The following is a description of a gene set: We report the application of single-molecule-based sequencing technology for high-throughput profiling of histone modifications in mammalian cells. By obtaining over four billion bases of sequence from chromatin immunoprecipitated DNA, we generated genome-wide chromatin-state maps of mouse embryonic stem cells, neural progenitor cells and embryonic fibroblasts. We find that lysine 4 and lysine 27 trimethylation effectively discriminates genes that are expressed, poised for expression, or stably repressed, and therefore reflect cell state and lineage potential. Lysine 36 trimethylation marks primary coding and non-coding transcripts, facilitating gene annotation. Trimethylation of lysine 9 and lysine 20 is detected at satellite, telomeric and active long-terminal repeats, and can spread into proximal unique sequences. Lysine 4 and lysine 9 trimethylation marks imprinting control regions. Finally, we show that chromatin state can be read in an allele-specific manner by using single nucleotide polymorphisms. This study provides a framework for the application of comprehensive chromatin profiling towards characterization of diverse mammalian cell populations. studied in species Mus musculus Human Gene Set: MIKKELSEN_ES_ICP_WITH_H3K4ME3 from publication Mikkelsen TS, Ku M, Jaffe DB, Issac B, Lieberman E, Giannoukos G, Alvarez P, Brockman W, Kim TK, Koche RP, Lee W, Mendenhall E, O'Donovan A, Presser A, Russ C, Xie X, Meissner A, Wernig M, Jaenisch R, Nusbaum C, Lander ES, Bernstein BE (PMID 17603471) Genes with intermediate-CpG-density (ICP) promoters bearing histone H3 K4 trimethylation mark (H3K4me3) in embryonic stem cells (ES)., and this is the list of marker genes: LRRC2, GJB5, TRMT10B, SMIM26, GPR143, UPK2, TRAF3IP2, NEIL1, FNDC11, EFCAB12, PBX1, SLC12A6, PYCARD, MED24, TOMM40L, CTNND1, ELMO1, MEGF10, SERPINI1, TCTN2, MPV17, GRN, ZNF276, MAPDA, MGST1, TRPV2, ZBTB4, FBXO16, OAS1, WDR38, DYNC2LI1, SPRED3, NME7, ADPRHL1 (ADP-ribosylhydrolase like 1), CYP2D6, PANK1, ACP3, LY6G6D, PPP2R5C, MVP, ASB15, WASHC3, TLR3, SCN9A, ZNF429, INTS9, DPP7, TMEM154, RCOR2, PM20D1, SACS, PCBD1, TRIM46, SLC22A18, HOGA1, RHBDL2, PRAMEF12, GALE, SETD1B (NCBI Gene Id 23067), TRAK1, RASSF6, GPRIN3 (NCBI Gene Id 285513), DRC3, MMACHC, SLC11A1, TCEAL1, PYROXD2, MTCL3, SLC4A10, SIPA1, LRRC74B, CLCN5, NQO1, ELMO3, CLIC1, SH3BGRL, OOEP, LPAR2, ZNF519, SERPING1, CHRNG, TULP2, PPP1R42, GOSR1, ATOSA, DNAH2, HSPB6, CPT1B, ARHGEF9, CROCC, AGMAT, PSD4, VPS50, SPARC, CAPN1, ZNF317, TCIM, RBM4, APOBEC3B, ADD3, ETV1, CBLN3, ZNF607, CD99L2, TCEAL8, RIN2, TRIM63, CTU1, G0S2, KCTD20, FIS1, NME5, CFAP52, FBXW7, RCN3, KATNAL2 (katanin catalytic subunit A1 like 2), NRSN2, RFTN2, C11orf52, RIOK2, SMUG1, CCDC68, KLC3, AASS, ZFP82, TSPOAP1, CHM, GYPA, TMEM119, SLC17A9 (NCBI Gene Id 63910), ACTR6, NFE2, DYNLT4, SLC44A4, TMEM82, S100A1, INHBE, GAP43, ZC3H12D, RDH12, IDNK, RAB13 (RAB13, member RAS oncogene family), NUDT13, C16orf54, AOX1, SCARF1, BLZF1, DNALI1, RLN2, GTF2H4, TMEM198B, GJB3, FOXH1, NSUN6, GDF3 (growth differentiation factor 3), CRYGN, USP49 (ubiquitin specific peptidase 49), NAT14, MST1, ALOXE3, FAM83E, DDX60, EMP1, MAMDC2, ACSL5, RECQL5, LARS1, GHDC, GSTT1, TLR2, MDH1B, ZFP42, SCN1A, PIERCE1, IL23A, PTER, RNF125, DAPP1, CFAP91 (cilia and flagella associated protein 91), IP6K2, LAT, CD3E, NCCRP1, ELF3, SLC12A3, MT3, LY96, DECR2, FKBP10, ZNF595, RAB19, TRIM29, GPX2 (NCBI Gene Id 2877), NHSL1, MCTS1, ABCD2, CRISPLD1, ABHD14B, CA3, ALDOC, NOBOX, OSGEPL1, PTGES, FASTKD2, MRGPRE, SLC37A4 (solute carrier family 37 member 4), CHRNA9, ARHGAP45, DLG4, PLIN3, APOOL, RTTN, SAT2, LIPH, POU5F1 (NCBI Gene Id 7934), SRRM3, CDH15, FKBP7, GMPPA, CCDC28B, TMEM63C, GSTM5, GEMIN6, DCLRE1C (NCBI Gene Id 64421), FAM13A, ASPRV1, TMEM45A, CPSF4L, RNF208, AGPAT4, ECHDC3, HSD17B11 (NCBI Gene Id 51170), INPP5J, ZNF415, SPHKAP, KCTD14, SLC35G6, CDC42EP5, LAMB2, FAM111A, PCYT1B, CCDC160, ANXA3, INHBC (inhibin subunit beta C), LIMA1, IGBP1, TRAF1, TIMM21, GNG2, THRSP, VPS41, C1QTNF5, TBKBP1, ZMYND8, ATP6V1G2, SSPN (NCBI Gene Id 8082), CPT1C, FUNDC2 (NCBI Gene Id 65991), TRIM6, ZCCHC13, P2RX7, OR2C1, CALD1, COX6B2, SCML4, FGR, CRYZL2P, FOXS1 (forkhead box S1), SLC9B1, LIN52, IGSF23, TBX6, ADM2, OPLAH, HRAS, MTMR11, RBP7, PHC1, GAB3, ZNF182, BMERB1, TMEM69, PCLAF (PCNA clamp associated factor), GPX8, PLEKHG1, BIVM, CD247, STC1, TCN2, RYR1, WDR83OS, FRRS1, TMEM14A, TAL2, SYT1, HESX1, TNFAIP6, C3orf52, SYT5, ZNF395, AADAT, CTSO (NCBI Gene Id 1519), CCDC93, ARMH4, WFDC2, FAM222B, TTC23, TXLNB (taxilin beta), GNG11, TMEM256, ATCAY, FLAD1, UPK3B, PADI4, ZNF260, ADIPOR2 (NCBI Gene Id 84751), TLK2, QPRT, SH3TC2, SLC38A7 (solute carrier family 38 member 7), ZP3, CWF19L2, KRT17 (NCBI Gene Id 5103), CFC1B, H1-6, LSG1, A2M (alpha-2-macroglobulin), OPRM1, SPN, DEF6, RBM41, HAPLN3, PRSS42P, DYNLRB2, TRAPPC13, PKP3, BBS1, TKFC, ARHGAP18, ALG3 (NCBI Gene Id 131416), ARHGAP30, DUSP19, SV2A, CXCL2, MBNL2, IRAG2, ZNF750, FUNDC1, HLA-DMA, PLIN2, UNC5CL, BRSK1, LIFR, PRCP, GSTM4, GRIA3, FAM186A (NCBI Gene Id 121006), SEMA3A, MYBPC2, TRIM16, IL15, LYSMD4, ERICH6, GID8, WDR12, GDF5, PBXIP1, MICAL1, IFT56, FITM1 (NCBI Gene Id 161247), RFX5, NRXN1, CCDC77, SLC9B2, LHCGR, NECTIN4, CHAC2, ZNF879, CNPY4, COL1A1 (NCBI Gene Id 4970), RIN1, ZC3HC1, ZIK1, LRRC34, RP2, FERRY3, ITM2A, UBASH3A, DENND2C, ABCC6, CASQ1, COL4A5 (collagen type IV alpha 5 chain), ZMAT5, RAD54L, ZSCAN10, AKR1E2, FANCD2OS, INHA, GDF15, LY6G6E, ABCA8, ALKBH8 (NCBI Gene Id 91801), FAM169BP, MEAK7, SUPT7L, ADAMTS4, MPST, XKR6 (XK related 6), CALHM2, FBP2 (fructose-bisphosphatase 2), RIPOR1, OSBPL7, ZC4H2, HSPA1L, CD38, NOL8, ALDH1L1, ZFYVE26, BPGM, ZNF708, ENPP3, SLC7A3, RAI14, WDR24, TMEM242, EFHB, NRN1L, PYCR1, CRIPTO, RPL10, TMEM141, POLD4, HSPB8, CCDC39, CUTALP, PRRC2A, ANK2, IFITM3, ECH1, NR5A2, ZNF239 (zinc finger protein 239), MTHFR, HDAC6, TMEM139, ARHGAP8, KLC4, TNK1, CCDC141, LDHD, ZNF878, PTPRCAP, SMARCAL1, AKAP7, PATL2, TRIM54, SULF1, ATG4A, PCSK1, SERPINE1, TSNAXIP1, DCLRE1A, COL5A3, NICN1, BAK1, SLC44A2, GOLPH3L, CUL4B, ZNF585B, RDH11, SPP1, SFXN3, AXL, SYT3, CAMK1, C7orf25, RNF186, PLET1, TJP3, CMKLR2, TMC4 (NCBI Gene Id 147798), FLRT3, SYNJ2, IFIT2, AKAP6, CNKSR1, NPFFR2, LRRN4CL (NCBI Gene Id 221091), TTC12, LAMA2, DNAJC12, DGKB, KRT222, SPACA9, KCNA4, GLB1L2, HMG20A, DCAF4, ARHGEF15, NCKAP5, EOLA1, APOF, HFE, DGLUCY, ENTREP3, ATXN7L1, LIN28B, FN3K, S1PR4, FRG2B, NOSIP, MLPH, IFTAP, WBP1L, CYYR1, TPPP3, ENTPD1, NOP10, CPQ, TRIM2, ITIH5, ZKSCAN5, TOR1AIP2, FTSJ1, RBBP9 (RB binding protein 9, serine hydrolase), HYDIN, ABI3, MPI, SNX31, RPL19, ODAD1, TMEM125, TPP1, PGLYRP1, SERINC4, NXPE4, AK1, LPAR6, DNASE1L1, PAK6, TEK, AMH (anti-Mullerian hormone), CALCOCO2 (NCBI Gene Id 10241), PAFAH2, TFPI, METTL15, COL7A1, FBXO15, DPPA4, PLA2G10, KDM6B, CYB5R2, SH3BGR, PPP2R3C, CMKLR1, FAM149A, PABIR2, TCL1A, VWA5A, CEND1, ZNF235, CHRNB4 (cholinergic receptor nicotinic beta 4 subunit), DPPA3, PRPF31 (pre-mRNA processing factor 31), CEACAM21, DPPA2, POLR2K, KRT71, BST1, SUMF2, TRAPPC14, PIR, GRIK5, SYTL4, ALPK3, HYAL1, IRGM, PRSS35, PML, WDCP, UPB1, SCNM1, HMMR, ZNF740, CYP2J2, ENTPD3, FLRT1, PLAT, CELF3, ZNF205, ITGB7, FUT1, C9orf152, SPEF1, TTLL9, C1orf56, PLA2G2C, GASK1B, PON3, CACNG1, TACR2, LMOD1, PRIM1 (DNA primase subunit 1), MALL, JMJD8, ADAM18, GNGT2, RAD51B, DOCK9, SLC25A41, PAK1, ADHFE1, CA9, GCDH, BCL2L2, HNF1A, ZRANB3, DOK2, PBLD, DNAI3, DNAJC4, MORC2, KLHL5, CLEC2D, CSTPP1, C11orf65, PUS3, LRP1, P2RX3, DENND2B, NMRAL1 (NmrA like redox sensor 1), TGFB1I1, JADE1, TRIM10, MIOX, EHHADH, ACY1, STOML1, PRSS8, PGAM2, GLRA3, TMEM106A, TMEM184A (NCBI Gene Id 202915), CALHM5, STAT4, LYSMD1, NFKBID, GALM, ETFBKMT, CLDN14, ASB7, AKR1B10, SPMIP8, TRPA1, TFPT (TCF3 fusion partner), PLEKHG5, FASTKD1, SYN3, EHBP1 (EH domain binding protein 1), IFITM2, NUDT22, PHKG2, RBMS2, NDST1, TIMP1, FAM3A, PRR11, SLC2A10, KRT72, PLA2G12B, GSTP1, SAP30BP, KCND1 (potassium voltage-gated channel subfamily D member 1), DYNLT3, ZNF646, MTERF2, EGFL6, CYCTP, RESP18, C1QTNF1, SCML2, C5orf34, GBP6, THBS3, TUT1 (terminal uridylyl transferase 1, U6 snRNA-specific), CTNS, EID3 (EP300 interacting inhibitor of differentiation 3), ATP5MC1, RASGRP4, ZNF454, ANK3, FAIM2, CDA, CLDND2, GIPR, TMEM67, ZNF112, S100A13, HDGFL1, ACTN3, MOSPD1, CSRNP3, PLPP7, YPEL4, TCAF1, GRB7, TPCN2, CCDC65, CLDN9, ZSWIM9, TVP23A, SPSB3, FMR1NB, MRPL35, STPG1, LASP1NB, ARMC3, C8orf48, FKBP14, LGALS12, NPY4R, GDAP1L1, GJB4, TBC1D22B, LIPA, MFNG, EXOC4, SRGAP3, NAP1L2